Given this list of marker genes Hsp90ab1, Stat5b, Tuba1b, Il4ra, Alad, Parp14, Gata3, Mcm2, Xbp1, Lef1, Mir511, Rplp0, Fasn, Ptprc (NCBI Gene Id 19264), Rps2, Cited1, Nfil3, Impdh2, Cd300lf (CD300 molecule like family member F), Tcf7, Keap1, Shpk, Jak1, Il4, Pml, Stat6, Ccl11, Cdk4, Jak3, Stat5a, Adamts13 (ADAM metallopeptidase with thrombospondin type 1 motif 13), Rpl3, Xcl1, Cd40, Ptpn2 (protein tyrosine phosphatase, non-receptor type 2), Hspa5, Dcstamp, Mrc1, Coro1a, Rufy4, here is a description of the gene set: studied in species Mus musculus Mouse Gene Set: GOBP_RESPONSE_TO_INTERLEUKIN_4 Any process that results in a change in state or activity of a cell or an organism (in terms of movement, secretion, enzyme production, gene expression, etc.) as a result of an interleukin-4 stimulus.